Given this list of marker genes TSFM, PIR, ABCD4, GFPT1, PNPLA6, AKR1B1, GATAD1, MYO1E, ST13, KEAP1, BHLHE41, PAM, PLXNA1, GCLM, TRIM16, GPR107, C5orf15, SQOR, MYO1B, METTL3, AGRN, BDH1, MSMO1, GLA, KLHL12, RGP1, FDPS, TMEM255A, TRPM2, SDC2, CD59, ILRUN, ANKRD13C-DT, P4HA1, ASAP1, PILRA, DHCR24, MAP3K4, MGAT4B, MREG, ATP6V1H, GLYR1, ARSB, CCL22, SLC7A11, USO1 (USO1 vesicle transport factor), GSTM3, SEPTIN10, CLEC16A, RGL1, SLC39A6, CSTB, TUBB4B, CD209, CD80, NFE2L1, RASSF4, TGFA, TRMT1L, OPN3, RAB13, ZNF224 (NCBI Gene Id 7767), LRP8, PGD, UGP2, NUDT9, NMT2, NRBP1, HSP90AB1, EDEM2, NENF, EBI3, GLS (NCBI Gene Id 51679), FTH1, CLIC4, RASAL2, CYP27A1, NMRK1, KCTD7, CREBL2, ZNF767P, PDE4DIP, TXNRD1, SLC1A3, EOGT, ST3GAL2, VAC14, WSB2, PDSS1, RTP4, LRP12, NRP1, LPL, PRDX1, RFTN1, ABCA5, HSPB1, PSMB5, DTX2, NSUN3, SPECC1L, TBC1D2B, DSTNP2, NUP188, IL15RA, NIBAN1, FSCN1, EVL, PSMD1, STEAP3, CLN5, ACOT13, TBC1D13, MRC1, RDX, GTDC1, EHF, ATP6V1E1, MAOA, GOLGA3, CDK5RAP2 (CDK5 regulatory subunit associated protein 2), TNFRSF4 (TNF receptor superfamily member 4), PLA2G7 (NCBI Gene Id 7941), NHLRC2, ATP2C1, TXN, CKAP5, LAMP3, TNS3, SLAMF7, PPP6R2, PIP5K1C, APBA3 (NCBI Gene Id 9546), KLHDC10, ABHD4, NDUFAF1, INHBA, DNPH1, CALU, MITF, CD81, CTSL, ABCC1, CARM1, CLIC2, RRP1, CRIM1, LIMK1, TFPT, LSS, KCNN4, PPME1, UGCG, ZMYM6, TRIP11, ATXN1, SNX6, TUBB (NCBI Gene Id 95295), GABARAPL2, CPM, NDP, MGLL, C1QTNF1, GPD2, GPR137B, PCBD1, VCP, CHI3L1, TRIP10, PALS1, CYP27B1, MTX2, SUSD6, SLC11A2, STIP1, PARP12, ZMIZ2, TDP2, TAOK3, BRCA2, WNT5A, NECTIN2, CCDC88A, NQO1, DNAJA1, IL12B, MCM3AP, CD63, IGF2R, ZMYND8, NEFH, LPP (LIM domain containing preferred translocation partner in lipoma), HSD11B1, CSNK2A2, ACO1, PXDC1, BAZ1B, TWSG1, NEU1, PLGRKT, here is a description of the gene set: Leishmania major infected human dendritic cells (DCs) exhibit a marked induction of IL-12 ultimately promoting a robust Th1-mediated response associated with parasite killing and protective immunity. In this study, we utilized Affymetrix Genechips to globally assess the host cell genes and pathways associated with L. major infection during early infection (2, 4, 8, and 24 hrs) in human myeloid-derived DCs. Bioinformatic analyses of the hybridized microarray chips identified genes, represented by 848 unique probe sets, which, when compared to uninfected samples were observed to be significantly differentially expressed by one-way ANOVA. Altogether, the data provide a genome-wide perspective on the transcriptional influences Leishmania species exert within human DCs during early infection, and provides a platform for further investigations toward functionally characterizing candidate genes of importance to the IL-12 based immune response to infections. In the current study, we further investigate the L. major infected DC transcriptional during early time points after infection via microarray analysis. from publication Favila MA, Geraci NS, Zeng E, Harker B, Condon D, Cotton RN, Jayakumar A, Tripathi V, McDowell MA (PMID 24808365) Genes up-regulated in dendritic cells: untreated versus 4h after infection of Leishmania major. species: Homo sapiens Human Gene Set: GSE42088_UNINF_VS_LEISHMANIA_INF_DC_4H_UP